The following is a description of a gene set: part of: SLC transporter disorders studied in species Homo sapiens Four members of the SLC16A gene family encode classical monocarboxylate transporters MCT1-4. Widely expressed, they all function as proton-dependent transporters of monocarboxylic acids such as lactate and pyruvate and ketone bodies such as acetacetate and beta-hydroxybutyrate. These processes are crucial in the regulation of energy metabolism and acid-base homeostasis.<br><br>SLC16A1 encodes MCT1, a ubiquitiously expressed protein. Heterozygous defects in SLC16A1 were found in patients with symptomatic deficiency in lactate transport (SDLT aka erythrocyte lactate transporter defect; MIM:245340), resulting in an acidic intracellular environment and muscle degeneration with the release of myoglobin and creatine kinase. This defect could compromise extreme performance in otherwise healthy individuals.<br><br>SLC16A1 is essential for lactate transport in muscle cells. It is also highly enriched in astrocytes and oligodendroglia, neuroglia that support, insulate and provide energy metabolites to axons. Oligodendroglia dysfunction can lead to axon degeneration in several diseases. The cause is unknown but disruption of SLC16A1 transporter produces axon damage and neuron loss in animal and cell culture models. In humans, this transporter is reduced in patients with amyotrophic lateral sclerosis.<br><br>In cancer cells, a common change is the upregulation of glycolysis. The anti-cancer drug candidate 3-bromopyruvate (3-BrPA) can inhibit glycolysis through its uptake into cancer cells via SLC16A1 so it is the main determinant of 3-BrPA sensitivity in these cells. Reactome Pathway: Defective SLC16A1 causes symptomatic deficiency in lactate transport (SDLT), and this is the list of marker genes: SLC16A1, BSG